Given this list of marker genes KAT5, MIR30C1, SIK1, SCARB1, DGAT1, GK (glycerol kinase), AGPAT2 (NCBI Gene Id 681), CNEP1R1, SREBF1, LPIN1 (lipin 1), GPAT4, FBXW7, NR1H2, THRSP, NR1H3, MIR29B1, SLC27A1, SIRT1, GPAT3, GPLD1, PNPLA3, GPAT2, CTDNEP1, PCK1, MIR548P, MOGAT2, LPIN3, LDLR, LPIN2, PCK2 (NCBI Gene Id 5106), LPGAT1, DGAT2, PLIN5 (perilipin 5), TMX1, MFSD2A, ACSL1 (NCBI Gene Id 91249), MOGAT1, MOGAT3, AGMO, TMEM68, GPAM, C3, here is a description of the gene set: The chemical reactions and pathways resulting in the formation of a triglyceride, any triester of glycerol. Human Gene Set: GOBP_TRIGLYCERIDE_BIOSYNTHETIC_PROCESS studied in species Homo sapiens